Given this list of marker genes GRK6, ABCC1, HMOX1, GSR, ABCC2, GSTM4, TXN, NQO1, TXNRD1, PRDX1, GCLM, ME1, G6PD, GCLC, here is a description of the gene set: studied in species Homo sapiens Human Gene Set: SINGH_NFE2L2_TARGETS Nuclear factor erythroid-2-related factor 2 (Nrf2) is a redox-sensitive transcription factor that regulates the expression of electrophile and xenobiotic detoxification enzymes and efflux proteins, which confer cytoprotection against oxidative stress and apoptosis in normal cells. Loss of function mutations in the Nrf2 inhibitor, Kelch-like ECH-associated protein (Keap1), results in constitutive activation of Nrf2 function in non-small cell lung cancer. In this study, we show that constitutive activation of Nrf2 in lung cancer cells promotes tumorigenicity and contributes to chemoresistance by up-regulation of glutathione, thioredoxin, and the drug efflux pathways involved in detoxification of electrophiles and broad spectrum of drugs. RNAi-mediated reduction of Nrf2 expression in lung cancer cells induces generation of reactive oxygen species, suppresses tumor growth, and results in increased sensitivity to chemotherapeutic drug-induced cell death in vitro and in vivo. Inhibiting Nrf2 expression using naked siRNA duplexes in combination with carboplatin significantly inhibits tumor growth in a subcutaneous model of lung cancer. Thus, targeting Nrf2 activity in lung cancers, particularly those with Keap1 mutations, could be a promising strategy to inhibit tumor growth and circumvent chemoresistance. from publication Singh A, Boldin-Adamsky S, Thimmulappa RK, Rath SK, Ashush H, Coulter J, Blackford A, Goodman SN, Bunz F, Watson WH, Gabrielson E, Feinstein E, Biswal S (PMID 18829555) Selected electrophile and drug detoxication genes down-regulated in A549 and H460 cells (lung cancer) upon knockdown of NFE2L2 by RNAi.